The following is a description of a gene set: Mouse Gene Set: GOMF_CORE_PROMOTER_SEQUENCE_SPECIFIC_DNA_BINDING studied in species Mus musculus Binding to a sequence of DNA that is part of a core promoter region. The core promoter is composed of the transcription start site and binding sites for the RNA polymerase and the basal transcription machinery. The transcribed region might be described as a gene, cistron, or operon., and this is the list of marker genes: Rfx7, H3f3a, Rrn3, Nkx2-1, Ago2, Fendrr, Ar, Polr2a, Foxp1, H2az1, Smarcb1, Snapc3, Kcnip3, Fos, Ago1, Tbpl1, Tbp, Cebpb, Ezh2, Egr1, Gbx2, Pparg, Klf10, Stat1, Taf1, Jph2, Ruvbl2, Myc, Pax6, Mmp12, Isl1, Taf1b, Hdac1, Ubtf, Gtf2a1, Npm1, Bmyc, Rest, Hmga1, Pou2f1, Drap1, Nr3c1, Zbtb17, Taf1c, Rela, Gtf2b, H3f3b, Ubtfl1, Trp53